Given this list of marker genes RBMS3, ADRA1B, SCTR, LINC03051, LRRC52-AS1, ST6GALNAC5, LINC02024, OVCH1, MTMR12P1, UNC5C, CACNA1D, CADPS, NPAS3, NPY5R, MAPK10, LINC02126, MIR3659HG, TARID, KLHL13, LINC01916, LYPD6B, MYHAS, LINC00632, RPL21P99 (ribosomal protein L21 pseudogene 99), LRRC3B, RARB, CARMN, LRRC4C, PKNOX2, VLDLR-AS1, TACR3, LINC03000, P3H2-AS1, KBTBD11-OT1, CIBAR1-DT, ESRRG, PRR16, MIR1245A, LSAMP, CDH7, KCNMB2, MKX, TPH2, ENPP7P4, NPM1P10 (NCBI Gene Id 10837), GLIS3, PHACTR3, CNTNAP2, KLHL29, KCNIP1-OT1, ZNF804B, NR2F2-AS1, EYA1, DNM3OS, TMTC1, here is a description of the gene set: Human Gene Set: DESCARTES_FETAL_SPLEEN_STROMAL_CELLS from publication Cao J, O'Day DR, Pliner HA, Kingsley PD, Deng M, Daza RM, Zager MA, Aldinger KA, Blecher-Gonen R, Zhang F, Spielmann M, Palis J, Doherty D, Steemers FJ, Glass IA, Trapnell C, Shendure J (PMID 33184181) Marker genes curated from the annotated cluster as represented in the Descartes Human Gene Expression During Development database. The gene expression program underlying the specification of human cell types is of fundamental interest. The study authors generated human cell atlases of gene expression and chromatin accessibility in fetal tissues. For gene expression, the study authors applied three-level combinatorial indexing to >110 samples representing 15 organs, ultimately profiling ~4 million single cells. The study authors leveraged the literature and other atlases to identify and annotate hundreds of cell types and subtypes, both within and across tissues. Our analyses focused on organ-specific specializations of broadly distributed cell types (such as blood, endothelial, and epithelial), sites of fetal erythropoiesis (which notably included the adrenal gland), and integration with mouse developmental atlases (such as conserved specification of blood cells). These data represent a rich resource for the exploration of in vivo human gene expression in diverse tissues and cell types. studied in species Homo sapiens